The following is a description of a gene set: NOD2 is an intracellular receptor for the bacterial cell wall component muramyl dipeptide (MDP) and variants of NOD2 are associated with chronic inflammatory diseases of barrier organs e.g. Crohn disease, asthma and atopic eczema. It is known that activation of NOD2 induces a variety of inflammatory and antibacterial factors. The exact transcriptomal signatures that define the cellular programs downstream of NOD2 activation and the influence of the Crohn-associated variant L1007fsinsC are yet to be defined. To describe the MDP-induced activation program, we analyzed the transcriptomal reactions of isogenic HEK293 cells expressing NOD2wt or NOD2L1007fsinsC to stimulation with MDP. Importantly, a clear loss-of-function could be observed in the cells carrying the Crohn-associated variant L1007fsinsC, while the NOD2wt cells showed differential regulation of growth factors, chemokines and several antagonists of NF-κB, e.g. TNFAIP3 (A20) and IER3. Genes down-regulated in HEK293 cells expressing mutant NOD2: untreated versus muramyl dipeptide for 6h. studied in species Homo sapiens Human Gene Set: GSE22611_UNSTIM_VS_6H_MDP_STIM_MUTANT_NOD2_TRANSDUCED_HEK293T_CELL_DN from publication Billmann-Born S, Till A, Arlt A, Lipinski S, Sina C, Latiano A, Annese V, Häsler R, Kerick M, Manke T, Seegert D, Hanidu A, Schäfer H, van Heel D, Li J, Schreiber S, Rosenstiel P (PMID 21335489), and this is the list of marker genes: CT55, RBP1, POLD4, GATAD2A, PECAM1, DTX4, LMNA, CD302, SOS2, RUNDC3A, CALML4, AOAH, CORO1A, ADAM8, FURIN, ARHGAP28, CYLC1, SKIC8, MYL3, MEFV, RAMP1, PGBD5, MPPE1, ANKEF1 (NCBI Gene Id 63926), UNC5B, KCNF1, EGLN2, CLCN4, OR7A17, DNMBP, APEH (acylaminoacyl-peptide hydrolase), RAB3A, GPER1, GFOD2, ARHGAP33, SETD6, BEND5, VDR, MEF2C, HSPA1L, ADGRE2, SLC22A4, AMPD2, MRS2, PPP2R2D, RBBP9, SMAGP, C1QA, MAPK1, S100A4, LUZP2, EN2, BMP2 (bone morphogenetic protein 2), MNDA, CDA, HOXC13, ADARB2, SIPA1, ABCF1, ORC1, SLC26A4, ZNF516, FHL3, TACC3, IL13RA2, CSNK1E, B3GNTL1, BARX2, PIP4K2A, VIP, MRPL35, TRIM8, AKR1C4, BLTP1, WDR48, TBC1D2B, CTIF, RNPEP, PGF, PPP4R3A, ENSG00000289047, ETV6, VNN1, SLC25A14, PGLYRP1, ZNF174, GAB1, NKX3-2, RXRA, EDN2, MTMR6, TUBA4B, NFRKB, CNPY3, USP33, ARAP3, ALDH9A1, VAMP1, ABHD3 (abhydrolase domain containing 3, phospholipase), SEPTIN8, LRIG2, GPX3, TOPORS, KATNB1, GDF3, ADRA2C, KIF3C, TTC21B (NCBI Gene Id 79809), PXN, NACC2, GNL3LP1, PROC, B3GNT2, C2orf72, CRYGC, TYR, AGTPBP1, TNFRSF10B, TPO, TCAP, EHMT2, RNF141, DAPK2, STK17A, ZBTB14, RIN3, ENC1, AP4E1, MAMLD1, CAPZB, MT1E, NPHS2, SKI, LDLRAD4, DHRS7, KLHL25, UPF3A, COL19A1, PINK1, ZNF106, PIGF, ZNF350 (NCBI Gene Id 59348), SLC25A37, CDH17, SIGLEC7, KCTD12 (potassium channel tetramerization domain containing 12), PLS1, ENSG00000284948, GAPDHS, F2RL1 (F2R like trypsin receptor 1), TLR1, SYT1, NINJ2 (NCBI Gene Id 4815), GALK2, NARF, INKA2, TSC22D3, MAPK3, KIF18A, GNAT2, SLC39A2, MORN1, SYN1 (NCBI Gene Id 6853), VRTN, AKTIP, CLEC5A, NUP205 (nucleoporin 205), MAGEC3, SOX10, BSPRY, RNASE6, PBXIP1, SCAP, PCYT2, CNOT2, KLHL22, HNRNPU, CERS4, MON1B, CXCR2, E2F6, CPEB3, LRFN3, ST8SIA4, TNFRSF10C, FOLH1B, SLC25A42, GAD1, LINC00652, ADAMTSL3, ADCY8, TLE3 (TLE family member 3, transcriptional corepressor), POU5F1B, GPC3, ADGRE5, WDR45